The following is a description of a gene set: studied in species Mus musculus Mouse Gene Set: GOMF_2_IRON_2_SULFUR_CLUSTER_BINDING Binding to a 2 iron, 2 sulfur (2Fe-2S) cluster; this cluster consists of two iron atoms, with two inorganic sulfur atoms found between the irons and acting as bridging ligands., and this is the list of marker genes: Fech, Aox4, Ciapin1, AK157302, Glrx5, Uqcrfs1, Glrx2, Slc25a39, Ndufs1, Isca2, Aifm3, Fxn, Aox1, Iscu, Cisd3, Fdx1, Aox3, Cisd2, Cisd1, Aox2, Isca1, Rfesd, Sdhb, Xdh, ENSMUSG00000125816, Ndufv2, Fdx2, Cmah, Bola2